The following is a description of a gene set: Any process that stops, prevents, or reduces the frequency, rate or extent of macrophage apoptotic process. studied in species Mus musculus Mouse Gene Set: GOBP_NEGATIVE_REGULATION_OF_MACROPHAGE_APOPTOTIC_PROCESS, and this is the list of marker genes: Ghsr, Ccr5, Ccl5, Nod2, Selenos, St6gal1